Given this list of marker genes Unc13b, Rgs14, Cdk5, Nr3c1, Grid1, Rin1, Unc13c (unc-13 homolog C), here is a description of the gene set: Mouse Gene Set: GOBP_NEGATIVE_REGULATION_OF_SYNAPTIC_PLASTICITY studied in species Mus musculus A process that decreases synaptic plasticity, the ability of synapses to change as circumstances require. They may alter function, such as increasing or decreasing their sensitivity, or they may increase or decrease in actual numbers.